The following is a description of a gene set: studied in species Homo sapiens Human Gene Set: GOCC_PRE_SNORNP_COMPLEX A ribonucleoprotein complex that contains a precursor small nucleolar RNA (pre-snoRNA) and associated proteins, and forms during small nucleolar ribonucleoprotein complex (snoRNP) assembly. Pre-snoRNP complexes may contain proteins not found in the corresponding mature snoRNP complexes., and this is the list of marker genes: ZNHIT6, NOP56 (NOP56 ribonucleoprotein), ZNHIT3, NUFIP1, PIH1D1 (NCBI Gene Id 55011), TAF9, NOP58